The following is a description of a gene set: Reactome Pathway: Beta defensins part of: Defensins Humans have 38 beta-defensin genes plus 9-10 pseudogenes (details available on the HGNC website at http://www.genenames.org/genefamilies/DEFB). Many beta-defensins are encoded by recently duplicated genes giving rise to identical transcripts. Nomenclature is confusing and currently in transition. Uniprot recommended names are used throughout this pathway.<br>Many beta-defensins show expression that correlates with infection. All so far characterized beta-defensins, i.e. beta-defensin 1 (hBD1), 4A (hBD2), 103 (hBD3), 104 (hBD4), 106 (hBD6), 118 (hBD18) and 128 (hBD28) have antimicrobial properties. For beta-defensins 4A, 103 and 118 (hBD2, 3, and 18) this has been shown to correlate with membrane permeabilization effects. Electrostatic interaction and disruption of microbial membranes is widely believed to the primary mechanism of action for beta-defensins. Two models explain how membrane disruption takes place, the 'pore model' which postulates that beta-defensins form transmembrane pores in a similar manner to alpha-defensins, and the 'carpet model', which suggests that beta-defensins act as detergents. Beta-defensins contain 6 conserved cysteine residues that in beta-defensins 1, 4A and 103 (hBD1-3) are experimentally confirmed to be cross-linked 1-5, 2-4, 3-6. The canonical sequence for beta-defensins is x2-10Cx5-6(G/A)xCX3-4Cx9-13Cx4-7CCxn. Structurally they are similar to alpha-defensins but with much shorter pre-regions. Though dimerization of some beta-defensins has been reported this is not the case for all and it is unclear whether it is required for function. The majority of functional studies have focused on beta-defensin 103 (hBD3), which has the most significant antimicrobial activity at physiological salt concentrations. Beta-defensin 103 is highly cationic with a net charge of +11 e0. It exhibits broad-spectrum antimicrobial activity against gram-positive bacteria and some gram-negative bacteria, though some species are highly resistant. Sensitivity correlates with lipid composition of the membrane, with more negatively-charged lipids correlating with larger beta-defensin 103-induced changes in membrane capacitance. Though membrane disruption is widely believed to be the primary mechanism of action of beta-defensins they have other antimicrobial properties, such as inhibition of cell wall biosynthesis, and chemoattractant effects. The chemotactic activity of beta-defensins 1, 4A and 103 (hBD1-3) for memory T cells and immature DCs is mediated through binding to the chemokine receptor CCR6 and probably another unidentified Gi-coupled receptor. <br> <br>Like defensins, the human cathelicidin LL37 peptide is rich in positively-charged residues (Lehrer & Ganz 2002).<br>Expression of certain beta-defensins can be induced in response to various signals, such as bacteria, pathogen-associated molecular patterns (PAMPs), or proinflammatory cytokines. Like the alpha-defensins, copy number variation has been reported for DEFB4, DEFB103 and DEFB104 with individuals having 2-12 copies per diploid genome. In contrast DEFB1 does not show such variation but exhibits a number of SNPs. studied in species Homo sapiens, and this is the list of marker genes: CCR2, DEFB135, DEFB132, DEFB105A, DEFB116, DEFB134, DEFB104A, DEFB136, DEFB113, DEFB125, DEFB103A, DEFB124, DEFB127, DEFB1, DEFB108B, DEFB4A, DEFB115, DEFB106A, DEFB129, TLR1, DEFB133, DEFB118, DEFB126, DEFB107A, DEFB121, DEFB109B, TLR2, DEFB131A, DEFB114, DEFB123 (defensin beta 123), DEFB130A, DEFB112, DEFB119, DEFB117, DEFB130B, DEFB128, DEFB110, DEFB108A, CCR6